Given this list of marker genes CIBAR1, ERLEC1 (endoplasmic reticulum lectin 1), TRIM31, NR2C1, LBR, NARF, C1QTNF3, IDH1, RBPMS2, AK1, ERMP1, F5, LPIN1, BDH1, ADRB1, ERCC3, SLC11A2, STEAP2, HEBP2, MYCN, TREX1, TSC22D1, RRBP1, CFAP44, PIAS2, TMF1, PDE9A, FUT6, CTSL, ATP7B, ZNF710-AS1, GOLT1B, FAM83A, PHF20L1 (PHD finger protein 20 like 1), GPCPD1, SNX11, TMED5, LINC02875, ASIC1, C4orf19, ETFDH, TNFSF15, GOLGB1, SMIM31, EPN3, GALNT1, HMGCR, PLEKHH2, B3GNT3, MANSC1, TC2N, B3GALT5, WFDC2, SLCO2A1, STEAP1, TOX3, TMEM59, NR2F1-AS1, CDS1, SRD5A3, UGP2, CAST, COPZ2, ADD3, PDPK1, DMXL2, PTPRE, BHLHA15, LINC01798, PPARG, SLC2A13, MISP, MFSD11, NAMPT, RTP4, ARFGEF2, KLHL7, MUC13, TRAF4, TBC1D9B, CYP2C18, SQLE, S100P, NR4A2, COG6, RTTN, GOLPH3, ATP10B (NCBI Gene Id 80225), PAK6, KAT2B, CREB3L2, RAPH1, ST6GALNAC1, LMTK2, KIAA1671 (KIAA1671), TMEM165, GNE, CXCL8, ARHGAP5, SLC44A3, CRIM1, CYP1B1, MTUS1, PDIA6, BBS4, INAVA, AK3, SCOC, MIR570, RGL1, NSUN7, CTNNAL1, CPD, FBXO6, ERLIN1, TRAM1, PLEKHA7, SBF2, CRISP2, TSPAN3, CHD9NB, BACE2, DNAJC3, NTN4, IFNLR1, AMPD3, PTGFRN, LMBRD1, NKX3-1, GXYLT1, DGLUCY, PRR15, EVI5, FAM171A1, ACAD8, POPDC3, FUCA1, DHCR24, SEC11C, SASH1, GFPT1, PITPNA, XPNPEP1, DAZAP2, BRPF3, MIR34AHG, ZNF652, DCBLD1, EIF4EBP2, PTPN13, MFSD6, BDKRB2, MAP1LC3B, EML4, SELENOM, RAB1A, CMPK1, DOCK11, EEPD1, EYA2, PPL, ENTPD4, FZD5, ARHGAP26, AGFG2, DPY19L2, ST14, MARCHF3, SPAG1, UBR3, ETNK1, SLC44A5, PTPN3, HS3ST1, ATG4A, MGAT5, TOM1, DAP, RIOX2, PAG1, SEC63, ACER3, POR, RCAN1, ASAH1, TPST1, MTMR12, MPC1, SLC7A14, ACSL3, CCDC160, RIN2, FZD8, VOPP1, TGOLN2, PTPRJ, TBC1D2, RORA, TRNP1, MUC1, HEY1 (NCBI Gene Id 23462), RNF145, LIPA, GALNT5, APOO, BCAT1, CDC14B (cell division cycle 14B), SYNRG, FAM217B, CEACAM6 (CEA cell adhesion molecule 6), PELI2, SLC27A2, ACBD3, NEK6, SH3BGRL2, ATPAF1, STT3B, LRRC31, NOL4L, ARHGAP44, CEBPB, ETAA1, LYZ, IL13RA1, MTHFR, ACADM, EPB41L4B, IGF2BP2, SLC35D2, RDH14, CHN2, ALAS1, SLC51A, TMEM245, GALNT12, RAB40B, FGB, CRISP3, KRTCAP2, GSAP, YIPF1, SDCBP2, DTWD1, PSG4, FAM114A1, TMEM44, CDADC1, SCNN1A, CNOT11, BICDL2, DUSP4, OSBPL2 (oxysterol binding protein like 2), RAB26, FTH1, CRYBG3, ITM2C, OR7E47P, ACACA, KDM7A-DT, CXADR, TRAK1, LINC00342 (long intergenic non-protein coding RNA 342), TMTC1, EOGT, TSHZ1, RMC1, KCNS3, PRPF18, CPEB4, BLCAP, ARFGEF3, GPR107, CRIP1, SNCAIP, SMCO4, LPIN2, SIX2, SNX18, PCGF5 (NCBI Gene Id 84333), MGC32805, GRAMD2B, CYSRT1 (cysteine rich tail 1), STEAP4, KIAA0232, GDF15, ARHGEF28, HPS3, ACOX1, DESI2, ZNF320, ATP1B1, IFT172, MALT1, FAM199X, PCSK6, RPS6KA1, CDH26, HYCC2 (NCBI Gene Id 285172), MXRA7, ENSA, NRBF2, SPIRE2, SYT17, SH3RF1, LRIG3, TTLL4, CD63, DYRK2, GALNT7, RMDN3, SEC62, VIPR1, FRY, GALNT6, STAM2, ZHX1, VPS54, FAM3C, TRIP4, PPP2R2A, TMBIM6, GOLM1, WDFY1 (NCBI Gene Id 57590), NIBAN1, PAX9, ALDH1A3, LCOR, TANK, SLC16A14, GNB5, LIMCH1, SAT1, TMEM41A, TCEA3, SH2D4A, ADGRF1, SNTB1, C1GALT1, B4GALT4, SAR1A, RDH10, SYNJ2 (NCBI Gene Id 8871), S100A6, BEND7, ABCC3, SCGB2A1, WDR7, APPL2, PSPC1, DUSP6, NECAP1, AHR, CFB, TPCN1, GOLPH3L, TMC5, SLCO4A1 (solute carrier organic anion transporter family member 4A1), C4BPA, PLEKHS1, IFT20, STS (steroid sulfatase), SLC44A1, ELF5, CAPN5, CLDN12, CRIM1-DT, NCALD, CD164, SLC12A2, CYP3A5, CD55, STK39, SPAG4, PCTP, SGPP2, LIMD1, LRPAP1, BZW1, ATP2C2, KDELR2, PIK3AP1, LRRC8B (leucine rich repeat containing 8 VRAC subunit B), GNA14, STK17B, BTG1, KLHDC7A, TJP2, SOAT1, SLC25A16, IFNGR1, TTLL7, LCN2, LRP11, KCNE4, TSPAN1, NBL1, EHF, OR7E12P, INSIG1, GCC2, UXS1, TMPRSS2, ENTPD3, PIGA, SH3PXD2A, SLPI, GPR143, SLK, RFFL, IL20RA, MIA, FAM110C, CEACAM1, NME7, MFSD9, GABBR2, CALML4, APOL6, TVP23B, KRT23, OSBPL10, AIFM2, PTK6, NANOS1, OLFM4, MALL (mal, T cell differentiation protein like), AGTR1, PAK1, RIMKLA, RBKS, GBP3, SECTM1, BPIFA1, CTSV, VPS13C, SLC35A2, TBC1D8, FGD6, LY75, CCDC68, MFSD4A, MIA3, NSF, ABHD17C, PSG6, PGM1, ECHS1 (enoyl-CoA hydratase, short chain 1), MFSD1, LRATD1, BCAS1, CENPV, SMIM5, RPL7AP46, GNS, C3orf70, LEPROTL1, DOCK9, EAF2, SMAP2, H2BC4, ALG1, KCNG3, GALE, SERPINB9P1, ATP6V0B, PTPRH, CRYM, CAT, ZFAND2A (NCBI Gene Id 90637), BID, FAM13A, LIMK2, PTPRZ1, FBXO32, SOS1, TMEM123, ADGRL2, MUC20, USP6NL, CASP7, UQCRQ, LYSMD4, GK, CXCL17, CLMN, BPIFB1, ARFGAP3, PHTF2, MSMO1, IFNGR2, ATP8B1, WIPI1, TPRG1L, GRAMD4, MACROH2A1 (NCBI Gene Id 9555), MOSPD1, PPARA, SGMS1, SPRY1, MIGA1, INPP5A, ZMPSTE24, OAZ3, IDH2, STARD4, GMDS, SUSD1, HMGCS2, OCIAD2, DRAM2, RGPD5, SNX7, PDLIM5, TCN1, EPS8L2, BIN1, PPP1R3D, NR2F6, ELL2, TSPAN5, IKZF2, HIC2, CAPN2, LIPT2-AS1, PITX1, TAX1BP1, TMEM45B, LOX, TOR1B, TMEM263, HOXB2, PRKAB1, CTSLP8, RAB22A, PIK3R3, PRKCA, GNL3, RNF144A, GDE1, BAIAP2L1, GAREM1, SLC49A4, PDCL3P2, GPAT3, CAPS, CITED2, FRMD4B, PTPRN2, CCN2, TMCC1, IGFBP3, SMAD2, C1orf116, ETV6, H2AC18, CHUK, TMED7, GK5, TMTC2, DNAAF11, SEC24A, RNF228, PRKACB, EFNA5, BDNF, TLCD2 (TLC domain containing 2), CSRNP1, BMAL2, ATP8B4, PCDH8, PRRT3, SAR1B, ZNF875, SLC16A9, EIF2AK3, WDR72, CD46 (NCBI Gene Id 4272), CP, DENND2D, MEAF6, TTC13, ILDR1, NCEH1, OTUB2, PRKCH, CEACAM5, SLC4A11, SCYL3, GALNT3, MED23, LIF, SLC25A27, FDFT1, SLC2A12, FCGBP, CORO2A, PLIN5, ADAP1, CDC42EP3, ERCC1, GNAS, EPAS1, ACVR1C, RAB6B, SERPINB1, SEPTIN6, FER1L4, TNFAIP2, LGR4, CTSS, CLIC5, FUT3, C2orf72, FAM118B, NFU1, SLC37A1, STIM2, YIPF5, PIP5K1B, PFKFB2, CLDN23, GYG2, TACC2, ATG16L1, WDR45B, UAP1, ACAA1, TAFA5, MUC5AC, RGP1, CIB1, YPEL5, BAALC, DBI, FBXW2, UQCR10, FBN2, STK24, PGPEP1 (pyroglutamyl-peptidase I), ASPH, AUTS2, AGAP1, MEIS1, GSTA1 (glutathione S-transferase alpha 1), AMIGO1, TMEM163, B4GALT6, CCDC186, TNFRSF19, COL2A1, DTX4, ZNF503, UBE2J1, LONRF3, ARHGAP27, DRAM1, BTG3, DSCR8, ENTPD7, C3, MED8, SELENBP1, NR2F1, WSB2, RGS17, AOC1, LINC02889, QSOX1, S100A9, TM9SF3, CTTNBP2, ORMDL1, FAM107B, LIF-AS2, SLC31A1, PGRMC1, RFK, AKAP12, ANKS6, CLGN, ENC1, RAB27A, CNDP2, SLC25A20, SSTR5-AS1, IDI1, CYB5A, MAL2, CGN, NPC1, PDE5A, TAF1A-AS1, OR7E14P, MIOS, B3GNT7, IL1R1 (interleukin 1 receptor type 1), ZMYND8, KLHL2, INPP1, HSBP1, CDRT4, OAT, MYO5B, PDXDC1, NANS, RUNDC1, PLPP5, CLINT1, ANKMY2, ST3GAL1, GLT8D1, NIPA1, PRPSAP1, SCPEP1, CCN3, ARPC5L, HOXB-AS1, KRT20 (NCBI Gene Id 54474), PLD1, PPFIBP2, ELMO1, SGMS2, ACVR2A, LYN, PITPNM3, GPC4, SLC16A3, MACO1, here is a description of the gene set: The effectiveness of therapies targeting specific pathways in breast cancer, such as the estrogen receptor or HER2, is limited because many tumors manifest resistance, either de novo or acquired, during the course of treatment. To investigate molecular mechanisms of resistance, we used two xenograft models of estrogen receptor-positive (ER+) breast cancer, one with and one without HER2 overexpression (MCF7/HER2-18 and MCF7 wt, respectively). Mice with established tumors were assigned to the following treatment groups: estrogen supplementation (E2), estrogen deprivation (ED), ED plus tamoxifen (Tam), all with or without the epidermal growth factor receptor tyrosine kinase inhibitor gefitinib (G). Another group received ED plus the antiestrogen fulvestrant (MCF7 wt only). Tumors with acquired or de novo resistance to these endocrine therapies were profiled for gene expression and compared with tumors in the E2 control group. One class of genes underexpressed in endocrine-resistant tumors (relative to E2-treated tumors) were estrogen inducible in vitro and associated with ER+ human breast cancers (luminal subtype). Another class of genes overexpressed in tumors with acquired resistance in both models represented transcriptional targets of HER2 signaling and was associated with ER-/HER2+ human cancers (ERBB2+ subtype). A third class of genes overexpressed in MCF7/HER2-18 tumors exhibiting de novo resistance to tamoxifen was associated with ER+ human cancers but not with estrogen-regulated genes. Thus, in response to various endocrine therapy regimens, these xenograft breast tumors shut down classic estrogen signaling and activate alternative pathways such as HER2 that contribute to treatment resistance. Over time, the molecular phenotype of breast cancer can change. The 'group 3 set' of genes associated with acquired endocrine therapy resistance in breast tumors expressing ESR1 and ERBB2. from publication Creighton CJ, Massarweh S, Huang S, Tsimelzon A, Hilsenbeck SG, Osborne CK, Shou J, Malorni L, Schiff R (PMID 18794137) Human Gene Set: CREIGHTON_ENDOCRINE_THERAPY_RESISTANCE_3 species: Homo sapiens